The following is a description of a gene set: Human Gene Set: GOBP_LONG_CHAIN_FATTY_ACID_IMPORT_ACROSS_PLASMA_MEMBRANE The directed movement of a long-chain fatty acid from outside of a cell, across the plasma membrane and into the cytosol. A long-chain fatty acid has an aliphatic tail containing 13 to 22 carbons. species: Homo sapiens, and this is the list of marker genes: SLC2A1, ACSL5, SLC27A5, CD36, AKT1, SLC27A1, ACSL1, IRS2, THBS1, AKT2